The following is a description of a gene set: The chemical reactions and pathways resulting in the formation of glucans, polysaccharides consisting only of glucose residues. Mouse Gene Set: GOBP_GLUCAN_BIOSYNTHETIC_PROCESS species: Mus musculus, and this is the list of marker genes: Dyrk2, Per2 (period circadian clock 2), 1810024B03Rik, Ins1, Esrrb, Gyg1, Sorbs1 (sorbin and SH3 domain containing 1), Pask, Ppp1r3g, Ppp1r3a, Gys2, Gck, Irs2, Ppp1r3c, Prkag3, Igf2, Akt2, Ppp1r3f, Mtor, Ppp1r3e, Grb10, Epm2a, Pth, Gfpt1, Gsk3b, Epm2aip1, Inpp5k, Ins2, Akt1, Ugp2, Gbe1, Nr1d1, Enpp1, Ppp1r3b, Acadm, Ptges3, Ppp1cb, Ppp1ca, Pgm2, Gys1, Igf1, Irs1, Pgm1, C1qtnf2, Nhlrc1 (NCBI Gene Id 105193), Insr, Ppp1r3d